The following is a description of a gene set: Human Gene Set: SCHAEFFER_PROSTATE_DEVELOPMENT_AND_CANCER_BOX2_DN studied in species Mus musculus Early prostate development genes (down-regulated at 6 hr dihydrotestosterone) which are also down-regulated in high grade prostatic intraepithelial neoplasia (PIN) vs invasive cancer. from publication Schaeffer EM, Marchionni L, Huang Z, Simons B, Blackman A, Yu W, Parmigiani G, Berman DM (PMID 18794802) Cancer cells differentiate along specific lineages that largely determine their clinical and biologic behavior. Distinct cancer phenotypes from different cells and organs likely result from unique gene expression repertoires established in the embryo and maintained after malignant transformation. We used comprehensive gene expression analysis to examine this concept in the prostate, an organ with a tractable developmental program and a high propensity for cancer. We focused on gene expression in the murine prostate rudiment at three time points during the first 48 h of exposure to androgen, which initiates proliferation and invasion of prostate epithelial buds into surrounding urogenital sinus mesenchyme. Here, we show that androgen exposure regulates genes previously implicated in prostate carcinogenesis comprising pathways for the phosphatase and tensin homolog (PTEN), fibroblast growth factor (FGF)/mitogen-activated protein kinase (MAPK), and Wnt signaling along with cellular programs regulating such 'hallmarks' of cancer as angiogenesis, apoptosis, migration and proliferation. We found statistically significant evidence for novel androgen-induced gene regulation events that establish and/or maintain prostate cell fate. These include modulation of gene expression through microRNAs, expression of specific transcription factors, and regulation of their predicted targets. By querying public gene expression databases from other tissues, we found that rather than generally characterizing androgen exposure or epithelial budding, the early prostate development program more closely resembles the program for human prostate cancer. Most importantly, early androgen-regulated genes and functional themes associated with prostate development were highly enriched in contrasts between increasingly lethal forms of prostate cancer, confirming a 'reactivation' of embryonic pathways for proliferation and invasion in prostate cancer progression. Among the genes with the most significant links to the development and cancer, we highlight coordinate induction of the transcription factor Sox9 and suppression of the proapoptotic phospholipid-binding protein Annexin A1 that link early prostate development to early prostate carcinogenesis. These results credential early prostate development as a reliable and valid model system for the investigation of genes and pathways that drive prostate cancer., and this is the list of marker genes: CAST, TRIM8, YWHAE, PTGR1, FAP, SOX9, TLE1